The following is a description of a gene set: Mouse Gene Set: REACTOME_NEGATIVE_REGULATION_OF_FGFR3_SIGNALING Negative regulation of FGFR3 signaling studied in species Mus musculus, and this is the list of marker genes: Fgf2, Fgf8, Fgf16 (NCBI Gene Id 80903), Uba52, Grb2, Mapk3, Cbl, Fgfr3, Braf, Fgf23, Ptpn11, Frs2, Fgf20 (fibroblast growth factor 20), Fgf17, Uba52rt, Ubb, Mapk1 (mitogen-activated protein kinase 1), Fgf1, Rps27a, Fgf5, Ppp2r1a, Fgf9, Ppp2cb, Mknk1, Ppp2ca (protein phosphatase 2 (formerly 2A), catalytic subunit, alpha isoform), Fgf4 (fibroblast growth factor 4), Ubc, Src, Fgf18, Spry2